Given this list of marker genes BLOC1S2, KXD1, SNAPIN, BORCS8, BORCS6, BLOC1S1, BORCS7, BORCS5, here is a description of the gene set: Human Gene Set: GOCC_BORC_COMPLEX studied in species Homo sapiens A protein complex that is involved in positioning of the lysosome within the cytoplasm and which is composed of BLOC1S1, BLOC1S2, BORCS5, BORCS6, BORCS7, BORCS8, KXD1 and SNAPIN. The BORC complex recruits ARL8 at the cytosolic face of lysosomes and couples them to microtubule plus-end-directed kinesin motors.